Given this list of marker genes Crabp2, Krt7, Fundc2, Rpl22l1, Uqcr10, Ctsz, Myh4, Rps15a, Med21, Ppia, Msx2, Tomm7, Rpl17, Fem1a, Anp32e, Pttg1, Atp1a2, Tk1, Spp1, Ebp (EBP cholestenol delta-isomerase), Retreg1, Cth, Wfdc2, Sem1, here is a description of the gene set: The mammalian SIN3 complex consists of histone deacetylases (HDAC1, HDAC2), several known proteins (SAP30, N-CoR) and as yet unidentified proteins. Here we show that the mouse tetradecanoyl phorbol acetate induced sequence 7 (TIS7) protein is a novel transcriptional co-repressor that can associate with the SIN3 complex. We have identified tis7 as a gene that is up-regulated upon loss of polarity in a mouse mammary gland epithelial cell line expressing an estrogen-inducible c-JunER fusion protein. In unpolarized cells, TIS7 protein levels increase and TIS7 translocates into the nucleus. Overexpression of tis7 causes loss of polarity and represses a set of genes, as revealed by cDNA microarray analysis. We have shown that TIS7 protein interacts with several proteins of the SIN3 complex (mSin3B, HDAC1, N-CoR and SAP30) by yeast two-hybrid screening and co-immunoprecipitations. TIS7 co-immunoprecipitated HDAC complex is enzymatically active and represses a GAL4-dependent reporter transcription. The transcriptional repression of endogenous genes by tis7 overexpression is HDAC dependent. Thus, we propose TIS7 as a transcriptional co-repressor affecting the expression of specific genes in a HDAC activity-dependent manner during cell fate decisions, e.g. scattering. Mouse Gene Set: VIETOR_IFRD1_TARGETS from publication Vietor I, Vadivelu SK, Wick N, Hoffman R, Cotten M, Seiser C, Fialka I, Wunderlich W, Haase A, Korinkova G, Brosch G, Huber LA (PMID 12198164) Genes down-regulated in c-JunER cells (mammary gland epithelum) by overexpression of IFRD1 off an adenovirus vector. species: Mus musculus